The following is a description of a gene set: Movement-based tics affecting discrete muscle groups. Motor tics Human Gene Set: HP_MOTOR_TICS species: Homo sapiens, and this is the list of marker genes: GNB1, PDGFB, SLITRK1, HNRNPC, COASY, VPS13A, PTCHD1, KCNN2, HDC, GRIA1, CEP152, PANK2